Given this list of marker genes Ubb, Rps27a, Cd14, Ly96, Ticam2, Tab3, Tlr4 (NCBI Gene Id 21898), Tab2, Tab1, here is a description of the gene set: part of: TRIF (TICAM1)-mediated TLR4 signaling  Reactome Pathway: TRAF6-mediated induction of TAK1 complex within TLR4 complex electronically inferred by orthology from the curated human pathway This event has been computationally inferred from an event that has been demonstrated in another species.<p>The inference is based on the homology mapping from PANTHER. Briefly, reactions for which all involved PhysicalEntities (in input, output and catalyst) have a mapped orthologue/paralogue (for complexes at least 75% of components must have a mapping) are inferred to the other species. studied in species Mus musculus